The following is a description of a gene set: Human Gene Set: HP_DECREASED_ACHILLES_REFLEX Decreased intensity of the Achilles reflex (also known as the ankle jerk reflex), which can be elicited by tapping the tendon is tapped while the foot is dorsiflexed. Decreased Achilles reflex studied in species Homo sapiens, and this is the list of marker genes: IBA57 (iron-sulfur cluster assembly factor IBA57), PDK3, BICD2, GDAP1, CRYAB, MPV17, MTPAP, ADSS1, FBXO38 (NCBI Gene Id 81545), LDB3 (NCBI Gene Id 1219), PNPLA6, DYSF